The following is a description of a gene set: electronically inferred by orthology from the curated human pathway Reactome Pathway: TFAP2A acts as a transcriptional repressor during retinoic acid induced cell differentiation part of: Transcriptional regulation by the AP-2 (TFAP2) family of transcription factors studied in species Mus musculus This event has been computationally inferred from an event that has been demonstrated in another species.<p>The inference is based on the homology mapping from PANTHER. Briefly, reactions for which all involved PhysicalEntities (in input, output and catalyst) have a mapped orthologue/paralogue (for complexes at least 75% of components must have a mapping) are inferred to the other species., and this is the list of marker genes: Npm1, Tfap2a